The following is a description of a gene set: The process in which a precursor cell type acquires the specialized features of an alpha-beta T cell. An alpha-beta T cell is a T cell that expresses an alpha-beta T cell receptor complex. Mouse Gene Set: GOBP_ALPHA_BETA_T_CELL_DIFFERENTIATION studied in species Mus musculus, and this is the list of marker genes: Atp7a, Runx3, Ap3d1, Mir873a, Il12b, Txk, Gli3, Tbx21, Gimap1, Atf2, Gimap5, Sh3rf1, Cd69, Runx1, Tbk1, Shh, Syk, Rorc, Gadd45g, Klhl25 (NCBI Gene Id 76553), Tgfb1, Cracr2a, Bcl3, Ccl19, Hlx (NCBI Gene Id 15284), Irf4, Entpd7, Malt1, Il4, Ifng, Ctsl, Zbtb7b, Eomes, Ccr7 (C-C motif chemokine receptor 7), Loxl3, Kcnk18, Braf, Armc5 (armadillo repeat containing 5), Rpl22, Il2rg, Ncor1, Il2, Il18r1, Kmt2a, Slc4a2, Ccr6, Slamf6, Nlrp3, Rara, Rora, Bcl6, Socs5, Nfkbid, Mir326, H2-Ea, Abl2, Prdm1, Pik3r1, Nkx2-3, Gimap3, Ascl2, Nckap1l, Il23a, Igtp, Lilrb4b (NCBI Gene Id 14727), Pf4, Men1, Ankle1, Ptger4, Gata3, Myb, Cd83, Zap70, Prkcz, Rc3h2, Stat4, Il6, Opa1, Tnfsf18, Stat6, Ep300, Prr7, Ada, Tmem98, Ccr2, Gpr183, Il4ra, Socs1, Rhoa, Il27, Il18, Zc3h12a, Nfkbiz, Lilrb4a, Zfp683, Ap3b1, Kctd9, Bcl11b, Foxp3, Tnfsf8, Brd2, Tcf7, Lef1, Cd1d1, Fut7 (NCBI Gene Id 99110), Gpr18, Zfp35, Sema4a, Ccl20, Jak3, Itk, Pnp, Fosl2, Rsad2, Tox, Cbfb, Itpkb, Tgfbr2, Ihh, Anxa1, Spn, Abl1, Stat3, Batf, Irf1, Pax1, Mtor, Psap, Hmgb1, Nkap, Il6ra, Traj18, Tnfsf4, Il21, Ptcra, Psmb11, Blm, Ripk2, Bcl2, Brd4, Lgals1, Pla2g2d, Sash3, Relb, Otud5, Rc3h1, Shb, Mir301, Foxp1, Smad7, Satb1, Ly9